The following is a description of a gene set: studied in species Mus musculus Mouse Gene Set: GOBP_TRANSCRIPTION_DEPENDENT_TETHERING_OF_RNA_POLYMERASE_II_GENE_DNA_AT_NUCLEAR_PERIPHERY The chromosome organization process in which the DNA sequence containing a gene transcribed by RNA polymerase II is maintained in a specific location at the nuclear periphery. In S. cerevisiae, this process involves cis-acting DNA sequences such as the TATA box and upstream activating sequence (UAS) elements, trans-acting transcriptional activators, and also the 3'-UTR of the transcript., and this is the list of marker genes: Nup98, Nup107, Nup155, Ldb1, Nup133, Rae1, Pcid2